Given this list of marker genes LATS1, CDKN1A (NCBI Gene Id 1026), INCA1, CDK5RAP1, CDKN1B, CDKN2A, MEN1, CDKN1C, APC, LATS2, TFAP4, here is a description of the gene set: Any process that stops, prevents or reduces the frequency, rate or extent of cyclin-dependent protein kinase activity. studied in species Homo sapiens Human Gene Set: GOBP_NEGATIVE_REGULATION_OF_CYCLIN_DEPENDENT_PROTEIN_KINASE_ACTIVITY